Given this list of marker genes TRAPPC2, COL2A1, B3GAT3 (beta-1,3-glucuronyltransferase 3), EXTL3 (exostosin like glycosyltransferase 3), RPL13, RNU4ATAC (RNA, U4atac small nuclear), CHST3, here is a description of the gene set: Abnormal increase in size of one or more metaphyses. Human Gene Set: HP_ENLARGED_METAPHYSES Enlarged metaphyses studied in species Homo sapiens